Given this list of marker genes Nrg3 (neuregulin 3), Btc, Hras, Shc1, Yap1, Grb2, Ubb, Stat5a, Rps27a, Esr1, Erbb4, Psenen, Psen1, Egfr, here is a description of the gene set: studied in species Mus musculus Reactome Pathway: Signaling by ERBB4 electronically inferred by orthology from the curated human pathway part of: Signaling by Receptor Tyrosine Kinases This event has been computationally inferred from an event that has been demonstrated in another species.<p>The inference is based on the homology mapping from PANTHER. Briefly, reactions for which all involved PhysicalEntities (in input, output and catalyst) have a mapped orthologue/paralogue (for complexes at least 75% of components must have a mapping) are inferred to the other species.